The following is a description of a gene set: Mouse Gene Set: GOBP_POSITIVE_REGULATION_OF_PROTEIN_DEPOLYMERIZATION species: Mus musculus Any process that activates or increases the frequency, rate or extent of protein depolymerization., and this is the list of marker genes: Cfl2, F2rl1, Cracd, Dstn, Trpv4, Sema5a, Spast, Actn2, Wdr1, Htr1a, Plek, Aurkb, Vil1, Pdxp, Nes, Carmil2, Katnb1 (katanin p80 (WD40-containing) subunit B 1), Cfl1, Stmn2, Carmil1